Given this list of marker genes COL9A3, MATN1, COL9A2, COMP, COL9A1, MATN3, here is a description of the gene set: Human Gene Set: WP_MULTIPLE_EPIPHYSEAL_DYSPLASIA_AND_PSEUDOACHONDROPLASIA_GENES species: Homo sapiens Multiple epiphyseal dysplasia and pseudoachondroplasia genes